The following is a description of a gene set: Mouse Gene Set: CUI_T_CELL_CD4_IL12_RESPONSE_DN from publication Cui A, Huang T, Li S, Ma A, Pérez JL, Sander C, Keskin DB, Wu CJ, Fraenkel E, Hacohen N (PMID 38057668) studied in species Mus musculus Genes negatively differentially expressed in cell type: CD4+ T cell upon treatment with cytokine: IL-12 in mouse lymph nodes in vivo. Cytokines mediate cell-cell communication in the immune system and represent important therapeutic targets. A myriad of studies have highlighted their central role in immune function, yet we lack a global view of the cellular responses of each immune cell type to each cytokine. To address this gap, the authors created the Immune Dictionary, a compendium of single-cell transcriptomic profiles of more than 17 immune cell types in response to each of 86 cytokines (>1,400 cytokine-cell type combinations) in mouse lymph nodes in vivo. A cytokine-centric view of the dictionary revealed that most cytokines induce highly cell-type-specific responses. For example, the inflammatory cytokine interleukin-1β induces distinct gene programmes in almost every cell type. A cell-type-centric view of the dictionary identified more than 66 cytokine-driven cellular polarization states across immune cell types, including previously uncharacterized states such as an interleukin-18-induced polyfunctional natural killer cell state., and this is the list of marker genes: Igkc, Ccl5, Hspa1b, Cd74, Hspa1a